Given this list of marker genes OCA2, CEP85L, MYL4, SLC49A4, RNU6-1000P, LBR, RNU11, LMTK2, CTB-1I21.1 (uncharacterized CTB-1I21.1), WDR81, GDF15, RPAP3, ANKRD12, HOXC13, SLC8A2, LAMTOR1, ATP6AP1-DT (NCBI Gene Id 158960, ATP6AP1 divergent transcript), RAD9A (NCBI Gene Id 5883), NEMP1, NR2F6, LMNA, CD5, EPG5, ZFYVE26, GABARAP, LINC02959, STARD4, BCORL1, ACSM1, NSMCE2, APOM, QTRT1, DHX30, SP8, LINC01410, LINC02912, SAMD13, CIC, AFF4, SPNS1, NAA40, DDA1, ARHGEF15, RBM19, SELPLG, NUP188, AFF4-DT, SHPK, HSPBAP1, RNVU1-27, ZNF146, LINC01671, UBTF, ARHGEF17, FREM1, GNAQ, SLC36A1, TEX10, ALDH1A2, ZNF292, RCAN1, INHA, CLEC2B, CDC42EP4, GID4, COLGALT2, ATP11A, USP31, FRMD4A, PLXDC1, RRAGC, ETV4, NFE2L1, FAM241B, SLC35A5, ADARB1, U2SURP, OGT, MAFTRR, RNU6-700P, LINC01132, MBD5, RRAGC-DT, GRN, ARFGEF2, TMCO6, SLC38A5 (solute carrier family 38 member 5), POLDIP2, GRAMD1A, USP9X, LGALS8-AS1, SPRED1 (sprouty related EVH1 domain containing 1), PRKAR1B-AS2, ZNF546, SNORD49B, SNHG29, SLC36A4, LIN28A, MFNG, NSMAF, DRAP1, TFAP4, FAM21FP, MIR4314, TMEM74B, AMDHD2, BAX, E2F6, JPH2, ARHGAP6, DIXDC1 (DIX domain containing 1), IK, TOM1, CENPU, ZNF580, VEGFA, MTHFR, MXI1, FGD3, CDKN2C, ARHGAP28, SYT12, SPG21, NAGPA, CNGB1, SLC6A6, ATP6V0D1, ANP32E, RPUSD4, NFIB, DNAJC14, RPL26, MAP3K12, TMEM199, LMTK3, COMMD4, PPT1, SLC33A1, VOPP1, HDAC5, ARHGDIA, ERP29, CMIP, C11orf68, HOXB5, GALNS, VPS33A, VPS41, GUK1, MAD2L1BP, TAL1, BBX, CCN1, SMARCA2 (NCBI Gene Id 95083), RNASEK, NACAP10, LGR6, ADRA1A, GAL3ST4, CXCL2, TAT-AS1, MEIS2, GET4, OBSL1, ZNF585B, KDM6A, ENSG00000243004, KLHDC9, NFKBIE, BAZ2A (bromodomain adjacent to zinc finger domain 2A), PAFAH1B3 (platelet activating factor acetylhydrolase 1b catalytic subunit 3), CCDC26, ARSA, IFNAR1, ARRB2, APOLD1, SKAP2 (NCBI Gene Id 8935), HEXA, KDM4C, RCN1, CALB2, POLR1A, RAD52, GNPDA1, OFCC1, AHCYL2, ATP6V0D1-DT, AGTRAP, TLE3, RPL36AP2, LCK, BAG6, ZMIZ1-AS1, LINC01366, ZNF507, H2AC25, EFNA1, ALDH5A1, WDR25, MIR3154, LINC00652, CCDC187, GATB, GNA15, CLCN3 (chloride voltage-gated channel 3), CHM, HNRNPU, ISLR, SRP54, NCOR2, RICTOR, PTCH1, ITGA9-AS1, ZCCHC24, ARAP1, ATP6V1G1, RTN2, MFF-DT, RNVU1-21, DNAJC8, MFSD11, GET3, LINC01229, CLN3, RMND1, TSC22D4, PPM1H, ATG14, ZBTB18, TMCC2, SCRG1, SLC35B2, MFF, MEIS1, NPEPL1 (NCBI Gene Id 79716), IGF2R, BCL11B, NTHL1, RN7SKP140 (RN7SK pseudogene 140), CAPG, SGCA, HMBOX1, CTSA, ATP7A, MAP1LC3B, LINC02259, MACC1-AS1, ENSG00000272008, MSH5-SAPCD1, MIR4276, MITD1, IKBKE, ANKRD10, ATP6V0B (ATPase H+ transporting V0 subunit b), GBE1, HBP1, ATP1A3, MECOM, SMAD6, STX4 (syntaxin 4), C19orf47, GPRASP3, KAT5, AKR1C3, YJU2, SPPL3, RANBP1, KLHL12, ZNF440, PLA2G4C, ANKMY1, NSD2, TCP10L2, SCN5A, MED28, ZZZ3, TUBA1C, SH2D6, FBXO31, RNU2-17P, GNS, DDX51, DVL2, BCL7A, AGFG1, GAA, DLL3, ERC1, CDKL3, MCOLN1, SLC25A12, VAC14, ATG3, WASHC2C, TSKU-AS1, TMEM198B, FLNA, PTBP1, BICD1-AS1, BBC3, ABHD10 (abhydrolase domain containing 10, depalmitoylase), SUMF1, TPP1, MRPL30, MARCHF8, ZNF345, WDTC1-DT, MAX, GOLIM4, KCNIP2, TSC2, RAB5B, SLC2A14, RNU6-419P, CEP162 (centrosomal protein 162), RBFOX2, COMMD9, PRKCE, PDE8A, SP7, PPP1R14A, LACTB2, IFITM1, RGCC, RNF220, RNVU1-14, DNAJC11, TMEM131, SLC16A5, GPR85, PHF19, FN3KRP, LAMTOR3, ZFPM2-AS1, LIN54, PAQR9, CALY, MS4A18, STRN, TRMT1, VPS50, ATP6V1C1, PIGQ, FAHD1, AKR7A2, DNAJC13, HECTD3, LINC01503, GPATCH3, LIMS1, CAMK2D, ESPNL, HEXA-AS1, RNU5D-1, SELENON, MRPL1, ZNF260, COLEC11, TTI2, VPS11, ARHGEF1, ZNF391, SLC40A1, KLHL32, ARMT1, BRSK1, SMCR8, HNRNPH2, CPEB4, DENND1C, SLC44A1, MIR199B, CSNK2B, RAB7B, KCNN4, ATP6V0C, FAH, VPS11-DT, ERAP1, RNASEK-C17orf49, WBP2, FNIP1, FMNL1, LAT2, FAM21EP, UNC13A, ZNF131, HLA-DPA2, DMTN, SCN9A, FAM27B, FGD2, NDUFV2-AS1, ALG1, EHMT1, VANGL1, CHD4, ALDH3B2, ATXN1-AS1, UBE2Q1, MAFG, BCAN-AS2, GBA1, ITGA7, WWP2, CCDC66, GTF2A1-AS1, TSKU, SH2D3A, NFE2L1-DT, PAQR9-AS1, MIR3646, MAP3K13, SOCS5, FCHSD2, TSPOAP1-AS1, FYN, TMEM165, USP28, TCP10L, PXK, FAM118B, PGM5P4, UROD, CCDC171, ELOVL2-AS1, CNPPD1, NEURL2, NDUFA2 (NCBI Gene Id 4695), ZNF19, DIO3OS, GPAM, ADGRE5, MSH5 (mutS homolog 5), MBOAT7, USF2, ARHGAP12, SRFBP1, GCDH, ITGB2-AS1, GBA1LP (glucosylceramidase beta 1 like, pseudogene), TSPOAP1, GALC, TBX6, TSHZ2, PAX6, HMGB1, ILF3 (NCBI Gene Id 54783), SPOP, RNVU1-19, EFNA3, SRSF2, ZNF790, ENSG00000259881, NRSN2-AS1, ANKRD11, PLK5, RETREG2, GRIK1, LGALS8, RCBTB1, WASHC5 (WASH complex subunit 5), SMAP2, LCDR, ATP8A2, SPATS2L, ARAP3, CALN1, SLC31A2, RPRD1A, PRSS8, TUBA1A, PTTG1IP, BAHCC1, RNU6-821P, GUSBP12, OSBPL2, FZD9, CASC3, PPP6R1, BCL7C, NPTN, HERC3, RNF14P1, NOC4L, BCL2, RPL21P7, ZNF581, C4orf46P2, FRAT1, DHX35-DT, RRAGB, GLA, SIRT6 (NCBI Gene Id 51548), CTNS, GAB1, ATP6V1H, PCDH1, LINC01164, ARL8B, MAP2K3, SNX8, CABIN1, CBX8, CTSD, ATP6AP1, NFIX, IMPDH2, TLE2, RNVU1-4, TMEM116, VPS26A, LINC01234, CUTA, SNRPA, DPF1, LINC00649, SYN3, IL2RB, AVPR2, MAGEC3, STAT6, NRSN2, RASGRF2, CLCN6, DAZAP1, EEF2, GNPTG, SSR4P1, RNVU1-26, INTS9, SOX5, ADD3, LAMP1, HPS1, PNRC1, NAPA, TRAPPC2L, ENSG00000260288, KIRREL2, PNRC1-DT, DEF8, GTF2A1, FCMR, KCNH2, OPN4, ACTMAP, CDK4, SPSB1, SLC38A7, MFSD1, CTCFL, SIRT1 (sirtuin 1), AP5Z1, RUFY2, UBE2B, ADCK1, TSR3, METAP1D, PLD3, TPM4, BLK, SLC66A1, ISLR2, CIMIP5, IGHMBP2, CPLX1, MIR3189, GUSBP11, NOD2, TOP3A, AXL, ATPAF2, SSC5D, MINCR, BMF, BLOC1S1, PHF21A, FOXS1, EGR2, ZNF565, POGLUT1, PCGF1, ADRM1, NAB2, GLMP, MED28-DT, LINC00963, FNDC3A, MILIP, HCFC1R1, RFX1, FAF1, GIT2, RIMOC1, DOLK, WASHC2A, TMEM248, CARD10, UVRAG, PFKFB3 (NCBI Gene Id 5209), SBNO2, CPED1, CNOT2, MIPEPP1, CLCN7, SARS2, SPTBN4, LCNL1, HAGH, ESYT2, RAMP3, KLKB1, GUSB, PEPD, DIS3, RAB18, HSPBP1, CSF1, CASP8, LRRC37B, SORT1, DHX35, NFKB1, XKR9, ILF3-DT, LRRC37A3, FDX2, LINC02952, NUDCD3, PPP1R10P1, MIR5087, here is a description of the gene set: Human Gene Set: ZNF410_TARGET_GENES species: Homo sapiens Genes containing one or more binding sites for (ZNF410) in their promoter regions (TSS -1000,+100 bp) as identified by GTRD version 20.06 ChIP-seq harmonization. from publication Yevshin I, Sharipov R, Kolmykov S, Kondrakhin Y, Kolpakov F (PMID 30445619)